Given this list of marker genes SLC26A9, NUP93, PPP1R17, DOCK4, PTBP2, MIR4486, ZRANB3, MFAP4, LINC02971, MIR4527HG, RN7SKP92, UBA5, SIAH1, SHISA5P2, ACAD11, EMC4, MYBPHL, SP1, IGHV3-16, NOD2 (nucleotide binding oligomerization domain containing 2), SLC11A2, MTCO3P16, AKT2, PRANCR, BCRP2, LAMA4, CCM2, ATP11B, TBCD, NOTCH2P1, CAMKK1, SMG5, DAPL1, RUSC1-AS1 (RUSC1 antisense RNA 1), PLCB1, MROH1, TSPO, SEPTIN4-AS1, GPR151, MTND3P16, MIR623, AP1AR, NDRG1, SPAG6, SDC3 (syndecan 3), SPDYA, ZSWIM8-AS1, GLIPR1L2, SCARF1, LINC01489, MIR3914-2, TIAM2, FRRS1, RFC1, RUSC1, TAS2R13, R3HDM1, APBB3, ISCA1 (iron-sulfur cluster assembly 1), DLD, LIG3, LANCL2 (NCBI Gene Id 95548), SPTBN2, C2CD5, PSMA4, CD44, TRMU, OXCT1, DENND5A, RN7SKP8, ATG4C, CLIP2, TLN1, MIR151A, MTND6P11, UCP3, KRT73-AS1, here is a description of the gene set: from publication Yevshin I, Sharipov R, Kolmykov S, Kondrakhin Y, Kolpakov F (PMID 30445619) Genes containing one or more binding sites for (HOXD1) in their promoter regions (TSS -1000,+100 bp) as identified by GTRD version 20.06 ChIP-seq harmonization. species: Homo sapiens Human Gene Set: HOXD1_TARGET_GENES